Given this list of marker genes OPN1LW, OPA1, OPN1MW, DNM1L, C1QTNF5, OPA3, OPN1SW, NR2E3, RBP4, POC1B, GUCY2D, here is a description of the gene set: Human Gene Set: HP_ANOMALOUS_TRICHROMACY Individuals with anomalous trichromacy possess three types of cones, but one of the three types of cones has an abnormal spectral sensitivity compared to normal cones. Anomalous trichromacy studied in species Homo sapiens